Given this list of marker genes ATM, BRIP1, KAT5, RFC2, CHEK1, RAD51D, RMI1, RFC3, SEM1, TOPBP1, BARD1, ATR, RAD51B, NBN, XRCC2, RAD17, RAD50, RFC4, RAD1, ATRIP, EXO1, BLM, RPA3, MRE11, HUS1, RAD9A, RPA2, RBBP8, RMI2, RAD51C, RHNO1, RFC5, BRCA1, BRCA2, RAD9B, TOP3A, WRN, RAD51, DNA2, RPA1, here is a description of the gene set: Reactome Pathway: Presynaptic phase of homologous DNA pairing and strand exchange studied in species Homo sapiens The presynaptic phase of homologous DNA pairing and strand exchange during homologous recombination repair (HRR) begins with the displacement of RPA from ssDNA by the joint action of RAD51 and BRCA2. CHEK1-mediated phosphorylation of RAD51 and BRCA2 is needed for BRCA2-mediated nucleation of RAD51 on 3'-ssDNA overhangs, RPA displacement and formation of RAD51 nucleofilaments. Invasive RAD51 nucleofilaments are stabilized by the BCDX2 complex composed of RAD51B, RAD51C, RAD51D and XRCC2. part of: Homologous DNA Pairing and Strand Exchange